The following is a description of a gene set: Any anomaly of the structure of the femur. Human Gene Set: HP_ABNORMAL_FEMUR_MORPHOLOGY Abnormal femur morphology studied in species Homo sapiens, and this is the list of marker genes: CPLANE1, CYP27A1, RAD51C, IFIH1, IYD, TGFB3, XYLT1, DVL1, COL9A3, CHD7, TBXAS1, ARCN1, CBFB, GPC6, ADAMTSL2, SMARCAL1, PRG4, NEPRO, EIF2AK3, POR, COL1A2, RINT1, FBN1, CANT1, CCDC47, SRCAP, XRCC2, SLC12A2, COL11A1, COMP, BMPR1B, TTI1, DUOXA2, BICD2, FZD2, GJB2, RAD21, KIAA0586, PSAP (prosaposin), FIBP, PIK3C2A, TONSL, CSPP1, RUNX2, DYNC2I1, MATN3, KIFBP, COG1, SLC34A3, TNFRSF11B, TRPV6, MMP9, RAB33B, CLCN5, TINF2, CSGALNACT1, CFAP410, TREX1, TOMM7, MGAT2, BRCA1, TGDS, SRP54, SEMA3E, TGFB1, RAB34, SLC4A10, COG4, ERCC6, PAM16, GABBR1, LYSET, NKX3-2, ALG12, DYNC2H1, CYP2R1, RAB23, ATP6V0A2, MADD, COL9A2, HNRNPK, MEGF8, IHH, UBE2T, SLC39A13, COG8, BRIP1, AMMECR1, LBR, FKBP10, SLC10A7, FANCG, RAD51, FANCA, FANCC, BCR, TMEM53, RSPRY1, DYM, BGN (NCBI Gene Id 633), ORC1, TRIP11, TP53, PLOD2, HNRNPR, DVL3, GBA1, SLC35B2, TBX4, AIFM1, GALNS, CHST3, EFL1, LTBP3, SKIC3, TRPS1, SLC26A2, WNK3, FLNB, ATP7A, CREBBP, RASA1, EXT1, OTUD5, BMP1, BRCA2, POLR1A, HS2ST1, MAN2B1, PRKAR1A, ARSL, MEG3, TNFRSF11A, LMNA, PROP1, EZH2, PRKG2, LRP5, SLX4, AFF3, XYLT2, TENT5A, TMEM67, MBTPS1, UBE3C, ADAMTS2, CRTAP, ENPP1, PHLDB1, FLNA, LEMD3, HSPA9, SLC31A1, RPL13, FANCI, SETBP1, AGPS, HESX1, LAMA5, GNPNAT1, SALL4, FANCE, PEX5, SOX9, FAH, TBX15, HSPG2, EXOC6B, ARID1B, COL10A1, FANCM, LIFR, UBAP2L, MTHFS, CTC1, RTL1, EXTL3, P3H1, COL11A2, RPS6KA3, CHEK2 (checkpoint kinase 2), SCARB2, NRCAM, BMP4, NANS, SHOX, BHLHA9, GNPTAB, B4GALT7, WNT7A, IFNGR1, PHEX, CCN2, PI4KA, PCNT, POLR3A, RFWD3, ZMPSTE24, NFIX, EED, PDE4D, CYP27B1, GJB6, CRKL, LHX4 (NCBI Gene Id 89884), LEMD2, UFC1, TRPV4, CLCN7, NGLY1, BRF1 (BRF1 RNA polymerase III transcription initiation factor subunit), SBDS, GORAB, TMEM38B, CAMK2A, COL9A1, TAPT1, STXBP1, COL1A1, SUCLG1, SLC35A2, CDC6, POP1, RET, SIL1, UNC45A, TSHR, SERPINF1, FN1, FANCF, GJA1, GLI3, NEK9, TPO, SCARF2, DNAJC21, DLK1, CHD4, CCN6, DDRGK1, ERCC4, TG, B3GALT6, SERPINH1, KIF22, GTF2E2, LHX3, EP300, UFSP2, MAD2L2, ACTB, LMX1B, MMP13, ACVR1, PTH1R, SGMS2, RNU4ATAC, GNAS, KDELR2, FANCB, MAPK1, PLEKHM1, ANKH, IFT140, VDR, TSHB, RAB3GAP2, ORC6, TRAF3IP1, DUOX2, HNRNPH1, SLC5A5, COL27A1, POC1A, NEK8, KCNJ8, RBM8A, COL2A1, ATRX, ABCC9, FANCL, FGFR3, PLOD3, TRAPPC2, SLC2A10, PUF60 (poly(U) binding splicing factor 60), GDF5, PCYT1A, RMRP, GLA, CSF1R, GNPTG, PALB2, IDUA, FANCD2, EXT2, GLB1, TCIRG1, ACAN, DMP1, FUCA1, POU1F1, RB1, MTX2, WNT5A, FGFR2